Given this list of marker genes SLC16A2, NUMB, GPR161, PEG10, SHISA7, ZMAT2, MYH9, TLN2, PHLDB1, RBM38, NENF, RPS6KA5, DNAI1 (dynein axonemal intermediate chain 1), LALBA, PLEKHF2, RLN2, ADA2, JADE2, MEX3C, ABL2, CCL4L2, here is a description of the gene set: species: Homo sapiens from publication Chen Y, Wang X (PMID 31504780) Genes predicted to be targets of miRBase v22 microRNA hsa-miR-3649 in miRDB v6.0 with MirTarget v4 prediction scores > 80 (high confidence targets). Human Gene Set: MIR3649